Given this list of marker genes RAB3GAP2, ERI1, OTUD6B, COL3A1, PLAA, HYAL1, SMS, CBL, FLNC, ZFX, COL6A1, GORAB, COMP, COL5A1, CCN6, NLRP1 (NLR family pyrin domain containing 1), COL6A3, MED12, IFITM5, COL1A2, GNB2, KCNH1, PRR12, HNRNPDL, PPIB, COL1A1, BRAF, HDAC4, HRAS, PIGG, PROKR2, B3GALT6, CSGALNACT1, FGD1, TMCO1, ASAH1, SP7, NFASC, P4HTM, RPS6KA3, GNPTAB, LMX1B, YY1, COL12A1 (NCBI Gene Id 1304), RNF13, KRT1, FBN1, ESAM, COL6A2, PTDSS1, PKDCC, here is a description of the gene set: studied in species Homo sapiens Human Gene Set: HP_ABNORMALITY_OF_HAND_JOINT_MOBILITY Abnormality of hand joint mobility